Given this list of marker genes MT-ND4, GABRA1, PRKAR1B, CACNA1H, JRK, MT-CO1, MAPT, BPTF, ELN, MT-TS2, MLXIPL, MT-ND6, MT-TW, SLC2A3, DARS2, MT-ND5, GABRG2, NF1, POMT1, MT-ND1, HTT, MT-CO2, GABRB3, MT-TH (mitochondrially encoded tRNA-His (CAU/C)), ABCD1, MT-CO3, KCNC3, MT-TF, MT-TQ, NOTCH3, SLC2A1, ADA2, PMPCA, MT-TL1, PSMD12, here is a description of the gene set: Impaired visuospatial constructive cognition Reduced ability affecting mainly visuospatial cognition which may be tested using pattern construction (for example by Differential Ability Scales, which test a person's strengths and weaknesses across a range of intellectual abilities). species: Homo sapiens Human Gene Set: HP_IMPAIRED_VISUOSPATIAL_CONSTRUCTIVE_COGNITION